Given this list of marker genes UNC80, TBC1D23, HNRNPC, SLC9A6, ZSWIM6, HNRNPH2, DYRK1A, WDR26, PRKAR1B, NALCN, HDAC8, ATP10A, ASXL1, TASP1, RAB11B, ZEB2, UBE3A, SIN3A, KANSL1, ADSL, SNRPN, ADNP, SATB2, TCF4 (NCBI Gene Id 6925), OCA2, GRIK2, here is a description of the gene set: A conspicuously happy disposition, characterized by frequent smiling and laughing, which may be contextually inappropriate or unrelated to the situation. Human Gene Set: HP_HAPPY_DEMEANOR studied in species Homo sapiens Happy demeanor